The following is a description of a gene set: Human Gene Set: HP_EEG_WITH_IRREGULAR_GENERALIZED_SPIKE_AND_WAVE_COMPLEXES EEG shows spikes (<80 ms) and waves, which are recorded over the entire scalp and do not have a specific frequency. species: Homo sapiens EEG with irregular generalized spike and wave complexes, and this is the list of marker genes: TBC1D24, STARD7, SAMD12, AP2M1, NEXMIF, SLC2A1, SLC6A1, SYNGAP1, GABRG2, SRPX2, CHD2, SCN1A, GRIN2A